Given this list of marker genes Unc13b, Syt7, Pla2g5, Unc93b1 (NCBI Gene Id 54445), Tlr9, Snx3, Appl2, Slc9a9, Mtmr4, Appl1, Syt11, Syk, Rab5a, Rab31, Tlr7, here is a description of the gene set: A membrane-bounded intracellular vesicle as initially formed upon the ingestion of particulate material by phagocytosis. species: Mus musculus Mouse Gene Set: GOCC_EARLY_PHAGOSOME